Given this list of marker genes NEURL1B, MIB1, ADAM17, MIB2, NOTCH1, UBC, UBA52, DLL1, JAG1, UBB, RPS27A, ADAM10, JAG2, DLL4, NEURL1 (neuralized E3 ubiquitin protein ligase 1), here is a description of the gene set: Reactome Pathway: Constitutive Signaling by NOTCH1 HD Domain Mutants studied in species Homo sapiens The heterodimerization (HD) domain of NOTCH1, responsible for association of NOTCH1 extracellular and transmembrane regions after furin-mediated cleavage of NOTCH1 precursor, is one of the hotspots for gain-of-function NOTCH1 mutations in T-cell acute lymphoblastic leukemia (T-ALL). NOTCH1 HD domain mutants are responsive to ligand binding, but the activation (through cleavage of S2 and S3 sites and release of the intracellular domain NICD1) also happens spontaneously, in the absence of DLL and JAG ligands. The following NOTCH1 HD domain mutants were directly functionally studied by Malecki et al.: NOTCH1 V1576E, NOTCH1 F1592S, NOTCH1 L1593P, NOTCH1 L1596H, NOTCH1 R1598P, NOTCH1 I1616N, NOTCH1 I1616T, NOTCH1 V1676D, NOTCH1 L1678P, NOTCH1 I1680N, NOTCH1 A1701P and NOTCH1 I1718T; other frequent NOTCH1 HD domain mutants (NOTCH1 L1574P, NOTCH1 L1574Q and NOTCH1 L1600P) are assumed to behave in a similar way. part of: Signaling by NOTCH1 HD Domain Mutants in Cancer